The following is a description of a gene set: species: Homo sapiens Human Gene Set: GOBP_ENDOPLASMIC_RETICULUM_TUBULAR_NETWORK_MEMBRANE_ORGANIZATION A process that is carried out at the cellular level which results in the assembly, arrangement of constituent parts, or disassembly of the endoplasmic reticulum (ER) tubular network membrane., and this is the list of marker genes: ARL6IP1, ATL1, ATL3, ATL2 (NCBI Gene Id 64225), RTN4